Given this list of marker genes Slc6a17, Slc38a4, Slc38a3, Slc36a3, Slc38a2, Slc6a14, Slc3a2, Slc36a4, Slc6a6, Slc1a4, Slc7a8, Slc7a5, Slc36a1, Sfxn1, Slc38a1 (solute carrier family 38, member 1), Slc38a5, Slc36a2, Slc7a10, here is a description of the gene set: Mouse Gene Set: GOBP_ALANINE_TRANSPORT The directed movement of alanine, 2-aminopropanoic acid, into, out of or within a cell, or between cells, by means of some agent such as a transporter or pore. species: Mus musculus